Given this list of marker genes EHBP1, GRK5, ADAMTS12, CLMAT3 (NCBI Gene Id 101927096), LINC00498, LINC01169 (long intergenic non-protein coding RNA 1169), RPS12P5, NR1H4, MASP1, CCDC3, INS-IGF2, ARHGEF35-AS1, IGFBP3, ENSG00000233539, ABCA10, ADAMTSL1 (ADAMTS like 1), ANKS1A, DAAM2, UPB1, FBXO24 (F-box protein 24), HMBOX1, AGTR1, LINC00698, HS3ST3B1, ADAMTS9, BCAS3-AS1, SLC17A8, NEURL1B, RN7SL657P, PTH1R, LINC02880, RPS6KA6, RBMS3, DIO3OS, LAMB1, ADAMTS2, DENND2A, OR2A1-AS1, RPS2P44, CER1, ALPL, COLEC11, SEPTIN4-AS1, COLEC10 (collectin subfamily member 10), CCDC68, ADAMTS13, ANGPTL6, LINC02319, NBPF3, RN7SL751P, ROCK1P1, RBM46, B3GNTL1P1, HHIP, BMPR2, ADRA1B, COL25A1, DIO3, HGF, ALLC, CCBE1, IFITM10, ECM1, here is a description of the gene set: from publication Cao J, O'Day DR, Pliner HA, Kingsley PD, Deng M, Daza RM, Zager MA, Aldinger KA, Blecher-Gonen R, Zhang F, Spielmann M, Palis J, Doherty D, Steemers FJ, Glass IA, Trapnell C, Shendure J (PMID 33184181) Human Gene Set: DESCARTES_MAIN_FETAL_STELLATE_CELLS studied in species Homo sapiens Marker genes curated from the annotated cluster as represented in the Descartes Human Gene Expression During Development database. The gene expression program underlying the specification of human cell types is of fundamental interest. The study authors generated human cell atlases of gene expression and chromatin accessibility in fetal tissues. For gene expression, the study authors applied three-level combinatorial indexing to >110 samples representing 15 organs, ultimately profiling ~4 million single cells. The study authors leveraged the literature and other atlases to identify and annotate hundreds of cell types and subtypes, both within and across tissues. Our analyses focused on organ-specific specializations of broadly distributed cell types (such as blood, endothelial, and epithelial), sites of fetal erythropoiesis (which notably included the adrenal gland), and integration with mouse developmental atlases (such as conserved specification of blood cells). These data represent a rich resource for the exploration of in vivo human gene expression in diverse tissues and cell types.